The following is a description of a gene set: The process that results in the fusion of a phagosome, a vesicle formed by phagocytosis, with a lysosome. Mouse Gene Set: GOBP_PHAGOLYSOSOME_ASSEMBLY species: Mus musculus, and this is the list of marker genes: Rab7, P2rx7, Myo7a, Coro1a, Rab7b, Tmem175, Srpx, Cln3, Spg11, Syt7, Rab34, Arl8b, Rab14, Pikfyve, Rab39, Pla2g5, Rab20